Given this list of marker genes TNPO3, DACT1, BPNT1, CNRIP1, ZBED1, EP300, PALS2, HIPK1, WFDC10B, PDYN, EMC6, GTF3C5, RUFY3, GUCA2A, ITM2B, TRIM27, ANKRD13A, CGNL1, PLXNC1, PERP, WFDC10A, PLCL1, SLC30A7, SPIN1, MLANA, CARF, NAA25, PHLPP1, HOXC4, CNTNAP2, KLHL28, HMBS, TMTC2, FA2H, PANK3, LHFPL2, FIGN, ACTC1 (actin alpha cardiac muscle 1), SMDT1 (NCBI Gene Id 91689), ABCB5 (ATP binding cassette subfamily B member 5), ARL17A, PELI1, STC1, TIPARP, HEY1 (NCBI Gene Id 23462), NIPSNAP3B, PTGS2, REST, PAFAH1B2, TRIP11, ALDH1A3, CYP20A1, SEC63, VXN, SHISA2, ICA1L, PNISR, CLEC2B, DCUN1D4, ZNF652, GABRB2 (gamma-aminobutyric acid type A receptor subunit beta2), NEURL1B, TEX12, DDIT4L (NCBI Gene Id 115265), EYA4, ZNF365, ALDH1B1, FAM222B, PWWP2A, GBP5, LYRM1, PAK5, SNX30, FGB, ATP6V1G3, BIRC5, INSIG1, ELL2, GRAMD1C, TEAD1, SLC22A23, ZNF800, ZC3H8, ARGLU1, DIXDC1, ZNF704, USP4, NPR2, PADI3, RNF139, PPP6R3, REM1, VSIG1, NSFL1C, MAP3K1, EBF4, MYO1B, RGS22, HS3ST3B1 (heparan sulfate-glucosamine 3-sulfotransferase 3B1), ANKRD28, EXT1, RASSF8, NR2E3, SLC35F6, MLEC, NUAK2, CA13, ANKRD49, CEP41, HECTD2, ATF6, NEDD4L, NEUROD1, PCDHB12, UQCC1 (NCBI Gene Id 55245), SMARCA5, PUM1, ZDHHC5, PROS1, MARK1, TMEM266 (NCBI Gene Id 123591), CCNA2, HDAC9 (histone deacetylase 9), PARP2, USP28 (NCBI Gene Id 57646), DPH2, NUFIP1, FOLR1, GPR3, PRRX1, RUNDC3A, MAST4, ADGRL3, C2orf15, RNF103, KDM1B, STIM2, AIF1L, PIGY, ZBTB8A, VCF2, KAT6A, GABBR1, WDR26, USP3, C8orf58, CAPSL, SHTN1, ZC3H12C, SLC41A2, PCDHB13, NR2C2, BRD2, PROM2, SEZ6L2, CD2AP, EWSR1, AIG1, SOCS5 (NCBI Gene Id 9655), HOXB3, PPP1R15B, KLF12, CNEP1R1, SLC4A7, LIN9, PRELID3B, CLCF1, here is a description of the gene set: Human Gene Set: MIR29B_1_5P species: Homo sapiens Genes predicted to be targets of miRBase v22 microRNA hsa-miR-29b-1-5p in miRDB v6.0 with MirTarget v4 prediction scores > 80 (high confidence targets). from publication Chen Y, Wang X (PMID 31504780)